The following is a description of a gene set: from publication Sobolev O, Binda E, O'Farrell S, Lorenc A, Pradines J, Huang Y, Duffner J, Schulz R, Cason J, Zambon M, Malim MH, Peakman M, Cope A, Capila I, Kaundinya GV, Hayday AC (PMID 26726811) Adjuvanted vaccines afford invaluable protection against disease, and the molecular and cellular changes they induce offer direct insight into human immunobiology. Here we show that within 24 h of receiving adjuvanted swine flu vaccine, healthy individuals made expansive, complex molecular and cellular responses that included overt lymphoid as well as myeloid contributions. Unexpectedly, this early response was subtly but significantly different in people older than ~35 years. Wide-ranging adverse clinical events can seriously confound vaccine adoption, but whether there are immunological correlates of these is unknown. Here we identify a molecular signature of adverse events that was commonly associated with an existing B cell phenotype. Thus immunophenotypic variation among healthy humans may be manifest in complex pathophysiological responses. studied in species Homo sapiens Genes up-regulated in peripheral blood mononuclear cell responders vs nonresponders in adults (18-64) after exposure to Pandemrix, time point 7D Human Gene Set: SOBOLEV_PBMC_PANDEMRIX_AGE_18_64YO_RESPONDERS_VS_NONRESPONDERS_7DY_UP, and this is the list of marker genes: IGHV1-69, TNFRSF17 (NCBI Gene Id 608), KRT81, CD38, JCHAIN, FKBP11, TXNDC5, IGKC, SDC1, MANF, ERLEC1, MZB1, IGKV1D-8, SEC11C, GLDC, ITM2C, UCHL1, ELL2, IGLL1, IGHV3-48, TRAM2, GGH